Given this list of marker genes RPS27A, CLCA2, CLCN5, RAF1, SRI, ANO4, TRPV1, SGK2, TTYH1, UBC (ubiquitin C), TRPM1, CLIC2, CASQ1, CLCN3, STOM, ASPH, TRPM6, CALM1, ANO6, TRPV3, TRPC3, ANO2, RIPK1, TRPC5, CLCN7, CLCN1, TRPC6, TRPC4AP, TRPM2, BEST4, TPCN2, NEDD4L, TRPV4, ANO10, CLCNKB, ASIC4, ANO7, SLC9C2, ASIC2, SGK3, SCNN1B, TTYH3, RYR1, TPCN1, TRPM3, ASIC3, FKBP1B, TRPC1, WNK2, BEST2, CLCN6, CLCN4, TRPM8, TRDN, SLC9B2, ANO3, ASIC5, SLC9B1, SLC9C1, CLCA4, ANO1, TRPM4, NALCN, BEST3, WNK4, UNC80, TRPM7, RYR3, UBB, TRPC4, UBA52 (ubiquitin A-52 residue ribosomal protein fusion product 1), TRPC7, TRPV6, TRPA1, SCNN1D (sodium channel epithelial 1 subunit delta), ANO5, CASQ2, OSTM1, STOML3, MCOLN1, SCNN1G, MLKL, RIPK3, CLCN2, TRPV2, MCOLN3, SGK1, SLC17A3 (NCBI Gene Id 10786), CLCNKA, UNC79, WNK1, BEST1, TTYH2, ANO8, ANO9, TRPM5, ASIC1, RYR2, TSC22D3, BSND, WNK3, MCOLN2, TRPV5, SCNN1A, WWP1, CLCA1, here is a description of the gene set: Reactome Pathway: Stimuli-sensing channels studied in species Homo sapiens Ion channels that mediate sensations such as pain, warmth, cold, taste pressure and vision. Channels that mediate these sensations include acid-sensing ion channels (ASICs) (Wang & Xu 2011, Qadri et al. 2012, Deval et al. 2010) and the transient receptor potential channels (TRPCs). Many channels are sensitive to changes in calcium (Ca2+) levels, both inside and outside the cell. Examples are protein tweety homologs 2 and 3 (TTYH2, 3), bestrophins 1-4 (BEST1-4) and ryanodine receptor tetramers (RYRs). part of: Ion channel transport